Given this list of marker genes ACSL6, ZNF765, MRPS18C, PRKACB, RAPGEF6, RMI1, SYS1, PLXNB1, NEXMIF, ALDH6A1, DLL1, LHFPL1, PLAGL2, EIF3A, TRIM50, ALS2, SGIP1, PTHLH, RBM27, SYNC, IRF2BPL, PAN3, CPEB4, CALHM5, LARP1B, TLE4, AVL9, PEG10, PIKFYVE, TNFSF13B, EDEM1, MRPL35 (NCBI Gene Id 64980), CYP1B1, DENND6A, CENPK, HDAC2 (histone deacetylase 2), PRKCA, ATF1, LUC7L3, SLC35G1, LHFPL2, CNGB1, PLP1, CHSY1, TMEM182, RPS6KB1, NOL4, IDH1, CASTOR3P, ADCYAP1R1, SUZ12, ERICH3, RSPO2, RBM12B, SNX18, STRN3, OLIG3, here is a description of the gene set: species: Homo sapiens Genes predicted to be targets of miRBase v22 microRNA hsa-miR-500b-5p in miRDB v6.0 with MirTarget v4 prediction scores > 80 (high confidence targets). from publication Chen Y, Wang X (PMID 31504780) Human Gene Set: MIR500B_5P